Given this list of marker genes Pnp, Ampd3, Entpd1, Urah, Nt5e, Urad, Xdh, Slc29a1, Nt5c1b, Nt5c1a, Uox, Ada, here is a description of the gene set: Mouse Gene Set: GOBP_AMP_CATABOLIC_PROCESS The chemical reactions and pathways resulting in the breakdown of AMP, adenosine monophosphate. species: Mus musculus